Given this list of marker genes Ccl21e, Cxcl12, Creb3, Ccl21a, Defb6, Ccl21f, Ccl6, Defb48, Cxcl3, Defb3, S100a14, Itch, Cnih4, Stat1, Defb46, Nars1, Ccl26, Tff2, Ccl19-ps6, Ccl11, Defb11, Defb5, Stat3, Defb37, Xcl1, Cxcl15 (NCBI Gene Id 20309), Ccl27a, Cxcl14, Ccl17, Ccl19-ps5, Cx3cr1, Cxcl1, Defb7, Defb47, Ccl28, Defb39, Ccl21b, Ccl21d, Ccl24, Nup85, Ccl5, Ccl8, Defb33, Ccl12, Ccl7, Ccl4, Ccl3, Gpr15lg, Cx3cl1, Defb40, Ccl19, Defb15, Ccl2 (NCBI Gene Id 20296), Ccl9, Cxcl13, Ccl20, Cxcl16, Ccrl2, Defb10, Pf4, Cxcl10, Cklf, Defb14 (defensin beta 14), Cxcl9, Defb38, Ccl1, Ppbp, Ccl19-ps3, Ccl25, Jak1, Defb2, Cxcl5, Defb8, Cxcl11, Defb1, Gm6040, Cxcl17, Ccl27al, Defb4, Cxcl2, Nes, Ccl19-ps4, Msmp, Ccl22, Ccl27b, Defb34, Defb9, Ccl19-ps1, Ccr2, here is a description of the gene set: Binding to a chemokine receptor. Mouse Gene Set: GOMF_CHEMOKINE_RECEPTOR_BINDING species: Mus musculus